The following is a description of a gene set: from publication Schaefer CF, Anthony K, Krupa S, Buchoff J, Day M, Hannay T, Buetow KH (PMID 18832364) IL3-mediated signaling events Human Gene Set: PID_IL3_PATHWAY studied in species Homo sapiens, and this is the list of marker genes: GRB2 (NCBI Gene Id 80715), IL3, ID1, PRKACB, JAK2, CISH, OSM (NCBI Gene Id 5008), PIK3CA, GAB2, PRKACG, CEBPB, SHC1, STAT5A, PTPN11, YWHAZ, SRP9, PRKACA, YWHAG, PIK3R1, IL3RA, HDAC1, STAT5B, CNKSR1, PIM1, CSF2RB, BCL2L1